Given this list of marker genes Slc1a7, Slc1a1, Slc1a3, Slc1a6, Slc1a2, here is a description of the gene set: species: Mus musculus Mouse Gene Set: GOMF_GLUTAMATE_SODIUM_SYMPORTER_ACTIVITY Enables the transfer of a solute or solutes from one side of a membrane to the other according to the reaction: glutamate(out) + Na+(out) = glutamate(in) + Na+(in).